The following is a description of a gene set: Mouse Gene Set: GOBP_FEMALE_SEX_DIFFERENTIATION The establishment of the sex of a female organism by physical differentiation. species: Mus musculus, and this is the list of marker genes: Ctnna1, Amhr2, Mir182, Mir124a-1hg, Nupr1, Sprr2d, Ccdc182, Fgf10, Lep, Wnt5a, Mir135a-2, Stra6, Scaper, Mir124-2hg, Kit, Sfrp1, Fancf, Nppc, Zfp830, Fanca, Mir471, Agt, Fzd4, Arrb2, Zp3, Esr1, Zfpm2, Casp2, Cebpb, Smad4, Kdr, Nos2, A2m, Tyro3, Foxo3, Mmp14, Lhb, Notch1, Taf4, Mmp2, Pcyt1b, Ereg, Bak1, Casp3, Inha, Vgf, Gdf9, 2610005L07Rik, Atm, Mir878, Dmc1, Tnfaip6 (NCBI Gene Id 21930), Fance, Mir743, Ubb, Bcl2, Hnrnpk, Umodl1, Insr, Stat5a, Mir741, Mmp19, Dmrta1, Afp, Ptx3, Nup107, Arrb1, Csmd1, Ptprn, Foxl2, Npr2, Esr2, Spo11, Mir880, Mir135a-1, Eif2b4, Ermp1, Zfx, Inhba, Mir96, Sohlh2, Fgf7, Oas1d (NCBI Gene Id 97256), Amh, Grk2, Lhfpl2, Dach2, Adrm1, Kitl, Gas2, Fst, Ahr, Rbp4, Lhcgr, Schip1, Fshb, Mir138-1, Sohlh1 (NCBI Gene Id 277551), Mir742, Mfn2, Rac1, Lsm14b, Sod1, Nr2f2, Axl, Bmp4, Idh1, Eif2b2, Nr5a2, Stat5b, Pitx2, Mir881, Retn, Angpt1, Nr5a1, Slit3, Bcl2l1, Cyp19a1 (NCBI Gene Id 13075), Phb1, Wt1, Nobox, Adamts1, Lhx1, Chd7, Msh4, Sirt1, Bax, Hyal3 (hyaluronoglucosaminidase 3), Plekha1, Lrp2, Gnrh1, Fshr, Myh9, Vegfa, Lhx8, Gpr149, Tiparp, Wnt4, Mir138-2, Inhbb, Mertk, Serpine1, Foxc1, Fancg, Nos3, Adcyap1, Dach1, Pde4d, Eif2b5, Nefh, Edn2, Brca2, Src, Sgpl1, Pla2g4a, Tbx3, Pgr, Lhx9, Trp63, Immp2l, Runx1, Nrip1, Bcas2, Ptger4, Arid5b, Lfng, Ube3a, Pdgfra, Mir183, Bmpr1b, Srd5a2, Mir672, Kmt2b